The following is a description of a gene set: This study creates a compendium of gene expression in normal human tissues suitable as a reference for defining basic organ systems biology. Using oligonucleotide microarrays, we analyze 59 samples representing 19 distinct tissue types. Of approximately genes analyzed, genes are expressed in all tissue types and designated as housekeeping genes. These genes display significant variation in expression levels among tissues and are sufficient for discerning tissue-specific expression signatures, indicative of fundamental differences in biochemical processes. In addition, subsets of tissue-selective genes are identified that define key biological processes characterizing each organ. This compendium highlights similarities and differences among organ systems and different individuals and also provides a publicly available resource (Human Gene Expression Index, the HuGE Index, http://www.hugeindex.org) for future studies of pathophysiology. studied in species Homo sapiens from publication Hsiao LL, Dangond F, Yoshida T, Hong R, Jensen RV, Misra J, Dillon W, Lee KF, Clark KE, Haverty P, Weng Z, Mutter GL, Frosch MP, MacDonald ME, Milford EL, Crum CP, Bueno R, Pratt RE, Mahadevappa M, Warrington JA, Stephanopoulos G, Stephanopoulos G, Gullans SR (PMID 11773596) Human Gene Set: HSIAO_HOUSEKEEPING_GENES Housekeeping genes identified as expressed across 19 normal tissues., and this is the list of marker genes: PGAM1, RPS11, RPL27A, MT-RNR1, CANX, COX7A2, FAM193A, ILK, PSMB4, RACK1, SNRPN, ATP5F1C, SPCS2, PSMB5, EZR, LINC02967, ATF4, ACTB, RPS17, CASC3, UBA52, TRIM28, RPL29, CIRBP, RPS6 (NCBI Gene Id 92956), GLUL, EIF3F, RPL12, NPM1, RPS19, BECN1, TCEA1, RPS3A, HLA-E, RPA2, PABPC1, RPS28, CTDSP2, DAZAP2, NAP1L1, EEF2, HSP90AB1, PFN1, GNB1, NCOR2, RPS2, ATP5MC1, EIF3E, COX7C, CD164, DDX39B, HYAL2, HSPB1, SNRPD2, PSAP, PPIA, HDAC1, RPL7A (NCBI Gene Id 6130), PGK1, FTL, GPS2, EIF3C, ACTG1, JOSD1, CETN2, RPL37A, TXN, SLC25A3, C1QBP, FHL1, PHB2, RPS8, HMGB1, SF3B2, FBL, BUD31 (NCBI Gene Id 8896), EEF1G, MLF2, TMBIM6, NDUFA4, ARPC2, NEDD8, RPL21, RPS27A, RPS23, DUSP1, MORF4L2, RPL34 (ribosomal protein L34), HLA-DRA, HNRNPL, SF1, ATIC, ENO1, DYNLL1, PFDN5, ARHGAP1, PSD, UBB (NCBI Gene Id 91253), ATP5F1A, LASP1, CHI3L2, STOM, RPL31, RPLP1, HLA-B, PTP4A2, RPS3 (NCBI Gene Id 6188), PTPN6, CCND2, TAGLN2, FTH1, FMOD, RPL13, RPL18A, PIM1, PRDX6, RPSA (NCBI Gene Id 3921), NONO, RPL3, MDH1, PARP1, ARAF, RPL18, PSMC1, RPL7, ESD, LDHA, HMGN2, SERPINA3, MPRIP, MSN, UBC, STAT3, OAZ1, FLNA, HPN (hepsin), SEPTIN2, PSMD2 (NCBI Gene Id 5708), RPLP2, PDLIM1 (NCBI Gene Id 9124), CCR9, LGALS3, RPN2, GSTP1, LDHB, HTRA1, RAC1, TLE5, HINT1, CLTA, MGP, ATP5PB, RPS27, PSMB3, SQSTM1, EIF4G2, FUS, SEC61B, FYN, WARS1, SNRNP70, EIF4A2 (NCBI Gene Id 63124), EIF4A1 (eukaryotic translation initiation factor 4A1), PTDSS1, QARS1, XBP1, RPS10, HSPD1, RPS16, EEF1A1, TPR, PI4KA (NCBI Gene Id 5297), YWHAZ, NPC2, KARS1, AP3S1, RPL24, ZFP36, YWHAH, PEBP1, ITGB1, PSME1, RPS7, YWHAQ, CLIC1, RPL13A, GUSB, ANXA11, TMSB10, ATP5MC3, GPS1, RHOA, STMN1, RPS26, VDAC2, BCAP31, HLA-A, NDRG1, PTMA (NCBI Gene Id 91418), RPL17, CD74 (NCBI Gene Id 972), JUNB, ARHGDIB, NPIPA1, MGST2, EIF4H, ARF1, RPS21, RPLP0, DSTN, ITPK1, FUCA1, HLA-DOA, CSTB, SPTBN1, EEF1B2, CST3, ECHS1, COX10, RPL14 (ribosomal protein L14), SLC25A6, RPS18, RPL19, SLC25A5, MLH1, DDB1, ATOX1, RPL36A, ARF3, HLA-DPA1, DDT, GNAS, H2AZ1, COPA, OS9, UQCRH, BCLAF1 (NCBI Gene Id 9774), CFL1, GPX4, HLA-DQB1, RFTN1, CAP1, IFITM3, COX8A, TAX1BP1, UBA1, HSP90AA1, COX6A1, RPS15A, NACA, PCBP2, TRAF4, MYH9, GAPDH (glyceraldehyde-3-phosphate dehydrogenase), SURF1, ANXA2, CAST, CD81, RPL27 (NCBI Gene Id 6155), RPL35, RPL36AL, ERH, SET, CCNI, SON, COX6B1, CHKB, SLC6A8, NCL, CAPNS1, ATP5MC2, DVL3, CLTC, ZNF91, RPS25, FCGRT, COPS6, PRDX1, RPL4, RPS15, HLA-DQA1, BTG2, YBX1, MAZ, TMED10, LAMP1, ATP6V1F, RPL38, CD3E, CLU, CAPZA1, VPS72, BRD2 (NCBI Gene Id 9803), SERPINB6, UBE2D3, TMSB4X, TXNIP (NCBI Gene Id 10628), LGALS1, S100A10, EIF4A3, TUBBP1, CYB5R3, ALDOA, CTNNB1 (catenin beta 1), CCT4, B2M, RPS5, SELENOW, H3-3A, RPL8, AAMP, CES2, CALM2, RPL35A, TPT1, CSNK2B, XPO1, UQCRB, APLP2, NFKBIA, SSB, NDUFA12, FAS, RPL23, SSR2, YWHAB, RPS14, ANP32B, H2AC18, SARS1, PSMB6, DCTN2, POLR2L, CD34, USP11, CAPN2, UBE2C, RBPMS, PLP2, RPL39, IRAK1, VIM, ABLIM1, ARF4 (ADP ribosylation factor 4), RPL9P7, NCSTN, NDUFV2, DDX5, MARCKS, SOD1, RPL6, APEX1, HNRNPK, NFIB, DHPS, RPL11, AGPAT1, EEF1D, COX4I1, NPIPB3 (NCBI Gene Id 23117), FKBP4, RPL10A, ISG20, RER1, HNRNPC, ATP5F1B, GSTO1, RPL28, FKBP1A, ARL6IP1, RPL41, PSMD7 (proteasome 26S subunit, non-ATPase 7), PSMD8, IQGAP1, PSEN1, AARS1, RPL32 (NCBI Gene Id 6161), COX6C, EIF1, H3-3B, HNRNPA1, ACKR1, PSMB2, HNRNPF, JUND, RPS29 (ribosomal protein S29), MT2A, RPS9, FNTA, SRP14, IFITM1, KAT6A, GDI2, LTA4H, PAX6, COMT, CD63